The following is a description of a gene set: Human Gene Set: GOERING_BLOOD_HDL_CHOLESTEROL_QTL_CIS Top scoring cis-regulated QTL (quantitative trait loci) influencing blood levels of high-density lipoprotein (HDL) cholesterol. from publication Göring HH, Curran JE, Johnson MP, Dyer TD, Charlesworth J, Cole SA, Jowett JB, Abraham LJ, Rainwater DL, Comuzzie AG, Mahaney MC, Almasy L, MacCluer JW, Kissebah AH, Collier GR, Moses EK, Blangero J (PMID 17873875) Quantitative differences in gene expression are thought to contribute to phenotypic differences between individuals. We generated genome-wide transcriptional profiles of lymphocyte samples from 1,240 participants in the San Antonio Family Heart Study. The expression levels of 85% of the 19,648 detected autosomal transcripts were significantly heritable. Linkage analysis uncovered >1,000 cis-regulated transcripts at a false discovery rate of 5% and showed that the expression quantitative trait loci with the most significant linkage evidence are often located at the structural locus of a given transcript. To highlight the usefulness of this much-enlarged map of cis-regulated transcripts for the discovery of genes that influence complex traits in humans, as an example we selected high-density lipoprotein cholesterol concentration as a phenotype of clinical importance, and identified the cis-regulated vanin 1 (VNN1) gene as harboring sequence variants that influence high-density lipoprotein cholesterol concentrations. species: Homo sapiens, and this is the list of marker genes: HLA-DRB3, HLA-DRB5, RPS26, LINC00339, PPA2, LGALS2, TIMM10, RPL14, GSTM1, UBA52, TMEM176B, UTS2, IKZF1